The following is a description of a gene set: Any process that modulates the frequency, rate or extent of the chemical reactions and pathways resulting in the formation of acyl-CoA. Human Gene Set: GOBP_REGULATION_OF_ACYL_COA_BIOSYNTHETIC_PROCESS species: Homo sapiens, and this is the list of marker genes: PDK1, PDK2, PGK1, SNCA, BCKDK, TPK1, PDK3, PDK4